The following is a description of a gene set: studied in species Mus musculus The process in which the cardiac ventricle is generated and organized. A cardiac ventricle receives blood from a cardiac atrium and pumps it out of the heart. Mouse Gene Set: GOBP_CARDIAC_VENTRICLE_MORPHOGENESIS, and this is the list of marker genes: Sfrp2, Dll4, Rxra, Sox4, Tbx5, Bmpr1a, Pou4f1, Smad4, Hey1, Hand2, Nkx2-5, Hif1a, Smarcd3, Lrp2, Tgfbr2, Myl2, Bmp10, Chd7, Tgfb1, Foxc2, Smad7, Ctnnb1, Mesp1, Heyl, Grhl2, Hand2os1 (Hand2, opposite strand 1), Mybpc3, Tnnt2, Tgfb2, Nrg1, Notch1, Rbpj, Pkp2, Foxf1, Cpe, Naglu, Epor, Epo, Sema3c, Ptcd2, Ahr, Myh6, Isl1, Eva1a, Rnls, Ppp1r13l, Tnni1, Npy5r, Klk1b1, Foxh1, Med1, Ryr2, Prox1, Gata3, Jag1, Tnnc1, Heg1, Bmp4, Fgfr2, Ednra, Eng, Col11a1, Tgfbr3, Myl3, Mef2c, Fkbp1a, Nog, Npy2r, Tnni3, Tgfbr1, Ly6e, Zfpm2, Pcdha9, Ccm2l, Dsp, Foxc1, Tpm1, Hey2, Fgf9, Tbx20, Gata4, Ube4b, Hand1, Gsk3a, Myh7